Given this list of marker genes TNIP3, CFI (complement factor I), MT1X, ZNF169, P4HA1, ZFR, RGS5, EYA3, NIPA2, TRIM14, FGFR3, ZNF512, GPX1, KCNK4, MIS12, SLC6A5, ANO6, SLC25A3, CYTL1, BMPR1B (NCBI Gene Id 658), KCTD1, WEE1, C2orf49, SWAP70, HNRNPH3, GARRE1, SELENOT, ZNG1A, NOL9, SLC13A4, SMAD6, KIT, AGAP2-AS1, TSPAN3, APH1B, NEK6, HCRT, MAPRE1, ZW10, DNAJB9, SLC25A15, TMT1A, ITGB1, MBLAC1, WSB2, ZNF30, KBTBD11 (kelch repeat and BTB domain containing 11), NOLC1, TM2D2, SEPHS1, L3MBTL4, ARIH1, LRG1, FCER1G, SPRY4, SLC26A2, MFSD1, RFESD, MCM9, TXNDC9, ZBTB21 (zinc finger and BTB domain containing 21), SSR2, TIGAR, PRKCI, CBFB, CDK15, RALGAPB, LTC4S (leukotriene C4 synthase), NPC2, DHX15, TSEN2, YARS2, LINC01148, MRPL36, SEC14L1, CD8A, PRMT9, RPS3, MBTPS2, TCL6, BOD1L1, GLB1, MFAP1, CD48, FBN2, RABEPK, VKORC1, NUP98, VPS54, ARCN1, AGO4, GRK3, DESI2, POLR3GL, PITPNA, BTF3, NACA, ZDHHC2, BCAM, ADAMDEC1, CDYL2, ARID1A, RSPH10B2, NOG, SLC8A2, CHRDL1, SEC23B, HLA-DPA1, ADRA2A, LSM11, ENSG00000253614, ZDHHC5, FAM174A, IDI2, ZSCAN12, GSX1, EBPL, ALDH18A1 (aldehyde dehydrogenase 18 family member A1), ZNF667-AS1, MARCHF5, RARS1, PCGF6, PIGT, CHMP4B, ZNF823, HINT3, PROM1, SLC7A9, UBL3, NOTCH2, PARP1, NRARP, NFIL3, HBS1L, ZNF627, NSD2, TRAPPC12, CRMP1, TMEM45A, LMLN, PSMB2, PRC1, NFS1, EIF2B2, CCDC6, AZI2, IL13RA2, MAD2L2, OTUD6B, SERPINB10, CASKIN1, SNHG6, PXMP4, POM121L8P, RAD51C, SARS1, MZB1, MIDEAS, USO1, CLEC4A, HEG1, RUFY1, SLC39A14, PRKAA1, ATOSA, TSC22D2, KIF2A, ZNHIT3, ALDH5A1, ENHO, PAG1, ME2, CEACAM6, EPDR1, ID3, OTUD1, SPRYD7, SEC63 (NCBI Gene Id 55399), HADHB, CELSR2, YIPF6, SGK3, MTPN, CD59, MSRB3, CALM1, TOMM22, DPYD, IFT52, BICDL1, FYTTD1, RPL19, AK3, RTP3, RDH10, DYNLT2B (dynein light chain Tctex-type 2B), RNASE3, SCN3B, here is a description of the gene set: Human Gene Set: GSE6259_BCELL_VS_CD4_TCELL_DN Genes down-regulated in B lymphocytes versus CD4 T cells. Dendritic cells (DCs) process and present self and foreign antigens to induce tolerance or immunity. In vitro models suggest that induction of immunity is controlled by regulating the presentation of antigen, but little is known about how DCs control antigen presentation in vivo. To examine antigen processing and presentation in vivo we specifically targeted antigens to the two major subsets of DCs using chimeric monoclonal antibodies. Unlike CD8+ DCs that express the cell surface protein CD205, CD8- DCs, which are positive for the 33D1 antigen, are specialized for presentation on MHC class II. This difference in antigen processing is intrinsic to the DC subsets and associated with increased expression of proteins associated with MHC processing. from publication Dudziak D, Kamphorst AO, Heidkamp GF, Buchholz VR, Trumpfheller C, Yamazaki S, Cheong C, Liu K, Lee HW, Park CG, Steinman RM, Nussenzweig MC (PMID 17204652) studied in species Homo sapiens